Given this list of marker genes ASS1, NMRAL1, ARG2, NAGS, OTC, SLC25A2, ARG1, ASL, SLC25A15, CPS1, here is a description of the gene set: Human Gene Set: REACTOME_UREA_CYCLE Urea cycle species: Homo sapiens